Given this list of marker genes TAL1, CROCCP2, XK, GYPA, CA2, ANK1, KEL, UROD, OSBP2, BNIP3L, ICAM4, PPOX, GCLM, DCAF11 (NCBI Gene Id 80344, DDB1 and CUL4 associated factor 11), GYPC, KLF1, GLRX5, SLC4A1, FECH, GYPB (glycophorin B (MNS blood group)), GYPE, RNF123, RAD23A, HMBS, TRIM10, UBAC1, HBD, HBQ1, CLIC2, SPTA1, NFE2, EPB42, SPTB, SELENBP1, GATA1, MARCHF8, RHCE, H4C3 (H4 clustered histone 3), TFDP1, RANBP10, CDC27, SNCA, SLC6A8, CTSE, H1-0, MINPP1, EIF1AY, MPP1, BLVRB, EIF2AK1, TSPAN5, NUDT4, AHSP, ALAD (aminolevulinate dehydratase), XPO7, TMCC2, BSG, TRAK2, HEBP1, CA1, NARF, KAT2B, ALAS2, TSPO2, MAP2K3, ACSL6, SLC22A4, FBXO7, ERMAP, FOXO3, PRDX2, SLC12A3, RHD, RHAG, here is a description of the gene set: Neighborhood of ANK1 ankyrin 1, erythrocytic in the GNF2 expression compendium Human Gene Set: GNF2_ANK1 Neighborhood of ANK1 species: Homo sapiens